The following is a description of a gene set: Human Gene Set: REACTOME_ACTIVATED_TAK1_MEDIATES_P38_MAPK_ACTIVATION activated TAK1 mediates p38 MAPK activation studied in species Homo sapiens, and this is the list of marker genes: MAPK11, IRAK2, MAPK14, MAP3K7, TAB1, TAB2, IKBKG, MAPKAPK2, IRAK1 (interleukin 1 receptor associated kinase 1), UBC, UBE2N, TRAF6, NOD1, TAB3, MAP2K3, UBB, RPS27A, UBE2V1, MAPKAPK3, MAP2K6, RIPK2, UBA52, NOD2